Given this list of marker genes PRKACB, NUP50, GREB1L, NOTO, TGFBR2, DNAAF1 (dynein axonemal assembly factor 1), C1orf54 (NCBI Gene Id 79630), LGR5, BCL10, CTHRC1, FOLR1, FGF10, HAND1, COL4A1, AGTR2 (angiotensin II receptor type 2), LRP5, NKX2-1, LGR4, HOXD11, COBL, MTSS1, WNT9B, HES5, KLHL3, MYC, RBM15, GPC3, KAT2A, NKX2-5, FZD6, IGF1, IHH, TMEM59L, ADAMTS16, SPINT1, SLIT2, RBPJ, SALL4, TBX3, GATA3, STK4, HOXB7, HHIP, DVL1, NRP1, RARG, WNK4, WNT1, PROX1, STK3 (serine/threonine kinase 3), SIX4, TBX2, MEF2C, SMAD4, TRAF6, HMGA2, NR3C1, RHOB, BTRC, GREM1 (NCBI Gene Id 7947), BMP7, CASP3, CTSZ, EFNB2, DLC1, HOXA5, SALL1, DLG1, CLUAP1, DDR1, RHOA, CTSH (NCBI Gene Id 1512), MTHFD1L, EDNRA, IFT57, TSC2, SOX9, MTHFR, PERP, CLIC4, WNT2B, DLG5, NOTCH2, EDN1, FOXA1, CC2D2A, PHB2, PODXL, MIR15B, RASIP1, GLI3, BCL2, MIB1 (MIB E3 ubiquitin protein ligase 1), SOX17, SPINT2, LMO4, CSNK2B, SOSTDC1, FOXP1, TFAP2C, MICAL2 (microtubule associated monooxygenase, calponin and LIM domain containing 2), MMRN2 (NCBI Gene Id 79812), ASB2, LAMA1, SDC4, EGF, NTN1, FOXH1, MSX2 (msh homeobox 2), ADAMTS12, WNT2, LEF1, TNF, SEMA4C, OPA1, GLI2, ETV5, MKKS, EXT1, BBS7, PTK7, WNT11, TCAP, BMP2, TGFB1, ABL1, HIF1A (NCBI Gene Id 3091), FOXD1, LHX2, GRHL2, PBX1, WT1, FKBPL, MESP1, PPP3R1, RYR2, HS3ST3A1, NOG, CASR, IFT122, TULP3 (TUB like protein 3), NOTCH1, FOXC2, PRICKLE1, CITED2, VANGL2, MYCN, CECR2, KRAS, TWIST1, DLL1, NOTCH4 (NCBI Gene Id 4855), SOX8, TIE1, ADM, WNT5A, CCM2, DVL2, SEC24B, SRF, FGF1, C2CD3, GLMN, ACVR1, RPS7, LCN2, PPP1CA, PHACTR4, STARD13, TCF21, APLNR, WNT3A (Wnt family member 3A), PTCH1, ENG, SFRP1, PSEN1, HAND2, SETDB2, DLL4, ESR1, CAV3, SIRT6, DCHS1, STIL, GATA4, MKS1, SPRY2, HS2ST1, CEP290, PGR, EYA1, NODAL, HES1, CDK20, YAP1, CSMD1, WNT4, GDF7, TSC1, AREG, FOXN4, AGT, PRKD2, NCKAP1, BBS5, FOXF1, MED12, SMAD3, RDH10, LIAS, SCRIB, MMP14, FGF8, MDK, BRD2, AHI1, PAK1, SUFU, RNF207, FZD3, AR, KIF26B, CTNNB1, CCL11, SOX18, RALA, ZEB2, SIX1, TIMELESS, CSF1R, KDM2B, MIR16-1, RET, NKX3-1, CITED1, KDR (kinase insert domain receptor), BSG, VDR, CXCL10, STOX1, ARHGAP35, CELSR1, MIR21, OVOL2, GDF2, EPHA2, CTNNBIP1, PKHD1, WNT6, HOXA11, MTHFD1, BMP5, KDM5B, CCDC39, EPHA4, VEGFA, SKI, TBX20, DAG1, SPECC1L, PKD2, RSPO2, PLXND1 (NCBI Gene Id 23652), RGMA, OSR1, GRHL3, TACSTD2, ARL13B, LZTS2, SLC39A12, VASP, APAF1, HESX1, KIF20B, ST14, PFN1, SRC, CCDC103, MEGF8, TRIM71, WDR83, NDRG4, ESRP2, LUZP1, BMP4, GBX2, ALX1, MAGED1, CSF1, HNF1B, SHH, ACVRL1, IRX1, FGFR2, NPHP3, GDNF, PIK3CD, SMO, TGFB2, HS3ST3B1, PKD1, PML, NRARP, MET, LBX1, CTNND1, PAX2, SFRP2, TEAD2, SPRY1, IFT52, NFATC4, BBS4, IFT172, LRP2, DEAF1, SIX2, ZIC3, FGF2, FUZ, EPHA7, PLXNB2, TCTN1, PAX8, GZF1, CCDC40, PITX2, SEMA3E, NPNT, ITGAX, CFL1, IRX3, PRKX, TNC, LHX1, MED1, RARA, IRX2, TMED2, PRKACA, GNA13, LAMA5, TGIF1, ILK (integrin linked kinase, NCBI Gene Id 55522), here is a description of the gene set: The process in which the anatomical structures of a tube are generated and organized from an epithelium. Epithelial tubes transport gases, liquids and cells from one site to another and form the basic structure of many organs and tissues, with tube shape and organization varying from the single-celled excretory organ in Caenorhabditis elegans to the branching trees of the mammalian kidney and insect tracheal system. Human Gene Set: GOBP_EPITHELIAL_TUBE_MORPHOGENESIS species: Homo sapiens